Given this list of marker genes TIPARP, DOK7, ZNF326, CMAHP, LRRFIP1, VGLL4, EED, SFT2D1, DSTN, CDC123, CBFA2T3, PCYOX1, ANKRD55, HIPK2, LLGL1, IL1R1, LPCAT1, HPS1, SFXN1, CROCCP2, FBXO3-DT, TMEM65, CDC23 (cell division cycle 23), NET1 (NCBI Gene Id 10276), SPDEF, SLC25A6, SYT7, ANKRD9, MTDH, MT2A, AZI2, RMI2, VPS4B, ST13, PCMTD1, ASNSD1, NIT1, DYNLL2, TMEM97 (NCBI Gene Id 27346), PAQR8, PDZK1, WEE1, LINC00869, BCAM, ZXDB, LITAF, ATP13A3, PACRG-AS3, SERTAD4, NUDT21, SKP2, RHOU, DPY19L1, BCOR, BCL7C, GPR158, SGK3, SOS1, CTDSP1, GTF2A1, LSM5, MOGS, NNT, BBLN, NAP1L1, LYRM7, CRYZL1, SLC2A4RG, PURG, NPIPA1, SPTBN1, RFX1, TMEM106B, NOA1, INIP, CPSF4, ZBED1, PACRGL, SELENBP1, CRIPT, CRLS1, FUBP1, EPM2AIP1, FBXL16, TRAF7, AKR7A2, LINC02984, DYRK1A, SLC25A48, TUG1, CREB3L2, TMEM120A, NABP1, SUSD2, PABPC1, CYB561, PITPNA, PDS5B, GLUL, ZNF430 (zinc finger protein 430), MLPH, CARD19, DDIT4, FOXP1, CFLAR, RAB10, NEBL, ENAH, S100A13, ANKS6, DLX1, RAD51D, MRPL30, PPP3R1, DNAL1, TFAP2C, PRR11, MB, CALR, PHB2, C21orf91, PRKAR1A (NCBI Gene Id 5573), GRN, SUB1, TTC3, SUSD4, RIN2, SOWAHC, SLC35A1, IGDCC3, NT5DC2, DELE1, PABPC1P3, USP6NL, RPUSD1, UBTD2 (ubiquitin domain containing 2), CENPK, CFL2, COTL1, LINC00865, LINC00662 (NCBI Gene Id 148189), RBMXL1, LTBP1, MRI1, TIAM1 (NCBI Gene Id 7074), FAM174A, ATG10 (NCBI Gene Id 83734), PRKCSH, UBL3, DHRS2, HELLS (NCBI Gene Id 55121), ARL17A, SYPL1, MTMR12, ACY1, AGR2, BOK, ATP1B1, ZMIZ1, RET, DCAF16, ACVR1B, MAP3K3, PROM2, KIF3A, LINC01667 (long intergenic non-protein coding RNA 1667), HSFY1, SREK1, ITFG1, NIPAL2, PM20D2, DNAJC1, CD151, FBXO8, LINC00938, DANCR, CCDC14, TFF3, CACNG4, HNRNPR, CECR2, PGK2, PCMT1, SMAD5, NDRG3, AURKAIP1, PTPRG-AS1, C19orf48P, BMP7, RNF144B, NEK6, INO80D, PDP1, LGALS8, SCAMP1 (NCBI Gene Id 9522), AKR7A3, GRHL2-DT, ARG2, GDPD1, MRPL33, PDRG1, PDCD4, SCUBE2, CPEB4, IGFBP2, TCAF1, MT1X, RALBP1, FIGN, MDM4, MINDY3, MBNL3, HMG20B (high mobility group 20B), PISD, MRPL10, H3-3A, HSP90B1, HACD3, UQCRB, PPHLN1, HNRNPA1, MACIR, AKT1, NUCKS1, MGC16275, ABHD17C, CTNNB1, TSPAN4, FREM2, RHOQ, ITPRID2, LNPK, TUBB, NRIP1, RSBN1L, TUSC3, THBS1, SLC10A3, ARHGEF12, SRSF4, ZMYM5, AHCY, F11R, NBPF14, OGT, ITPRIPL2, TM9SF2, DBI, ACTG1, GAS5, NLK, SERINC5, RGMB, SFPQ, TMEM50B, ARRDC4, PLGLB1, HNRNPUL1, ETV6, SMIM7, LPGAT1, DPY19L4, TSPAN32, NPM1P22, SLC2A1, CXCR4 (C-X-C motif chemokine receptor 4), AOPEP, TCF3, CNNM3, SNORD60, FAM20C, ARL5A, CENPX (centromere protein X), APIP, DUXAP8, CEBPA, ERGIC1, STK11, AK3, BCAP31, HNMT, HMGB1, RALGPS2, SCAI, NDRG1, SLC16A6, YIPF5, VRK2, OGG1, TMEM201, CBX3, ANKRD13D, NLN, RPE, MRPS25, FOXRED1, SERTAD1, KMT2C, CREB1, NAA25, MTA1, IFT25, NFIA, CROT, PHACTR2, ATXN10, STYK1, FSBP, ITGAV, CDCA2, E2F3, TUBA1A, CDC42SE1, MIR3682, CD47, DMTF1, TMEM135, MORF4L1, CSPP1, KBTBD4, ZFP36L2, MEGF9, ETS2, FBXO46, TSC22D1, VCF2, SOAT1, TLK1, DPAGT1, CNOT2, USP36, NSD2, WWP2, CDV3 (CDV3 homolog), EPB41L4A-AS1, BTBD2, MAX, ABTB2, NEAT1, RHOB, ATF5, CCDC149, GFM1 (G elongation factor mitochondrial 1), MAN1A2, SNX18, SNHG12, SMIM30, METTL26, H4C3, PIGM (phosphatidylinositol glycan anchor biosynthesis class M), NR2C2, SUMO1, N4BP2L2, AGPAT5, SRRT, MIPOL1, NT5DC1, ADAD1, PGRMC1, PGLYRP4, BBOF1, GLUD1, EMP2, RABL3, NECAB3, BCL6, TXNIP, STARD7, BCL11B, FRMD8, here is a description of the gene set: studied in species Homo sapiens Genes up-regulated in MCF7 cells (breast cancer) engineered to conditionally express LMO4 by a Tet Off system. from publication Wang N, Lin KK, Lu Z, Lam KS, Newton R, Xu X, Yu Z, Gill GN, Andersen B (PMID 17452977) The nuclear LIM-only protein 4 (LMO4) is upregulated in breast cancer, especially estrogen receptor-negative tumors, and its overexpression in mice leads to hyperplasia and tumor formation. Here, we show that deletion of LMO4 in the mammary glands of mice leads to impaired lobuloalveolar development due to decreased epithelial cell proliferation. With the goal of discovering potential LMO4-target genes, we also developed a conditional expression system in MCF-7 cells for both LMO4 and a dominant negative (DN) form of its co-regulator, cofactor of LIM domains (Clim/Ldb/Nli). We then used DNA microarrays to identify genes responsive to LMO4 and DN-Clim upregulation. One of the genes common to both data sets was bone morphogenic protein 7 (BMP7), whose expression is also significantly correlated with LMO4 transcript levels in a large dataset of human breast cancers, suggesting that BMP7 is a bona fide target gene of LMO4 in breast cancer. Inhibition of BMP7 partially blocks the effects of LMO4 on apoptosis, indicating that BMP7 mediates at least some functions of LMO4. Gene transfer studies show that LMO4 regulates the BMP7 promoter, and chromatin immunoprecipitation studies show that LMO4 and its cofactor Clim2 are recruited to the BMP7 promoter. Furthermore, we demonstrate that HDAC2 recruitment to the BMP7 promoter is inhibited by upregulation of LMO4 and that HDAC2 knockdown upregulates the promoter. These studies suggest a novel mechanism of action for LMO4: LMO4, Clim2 and HDAC2 are part of a transcriptional complex, and increased LMO4 levels can disrupt the complex, leading to decreased HDAC2 recruitment and increased promoter activity. Human Gene Set: WANG_LMO4_TARGETS_UP